The following is a description of a gene set: species: Homo sapiens Reactome Pathway: Norepinephrine Neurotransmitter Release Cycle Noradrenalin release cycle consists of reacidification of the empty clathrin sculpted monoamine transport vesicle, loading of dopamine into reacidified clathrin coated monamine transport vesicle, conversion of dopamine into Noradrenalin, docking and priming of the noradrenalin synaptic veiscle and then release of noradrenalin synaptic vesicle. In the peripheral nervous system in the peripheral nervous system noradrenalin is stored in large and small dense vesicles and is realesed from large vesicles. part of: Neurotransmitter release cycle, and this is the list of marker genes: PPFIA2, SLC22A1, VAMP2, RIMS1, UNC13B, SYT1, MAOA, PPFIA1, PPFIA3, PPFIA4, SLC22A2, SLC18A2, SNAP25, RAB3A, CPLX1, STXBP1, STX1A, TSPOAP1